The following is a description of a gene set: Any voltage-gated ion channel activity that is involved in regulation of postsynaptic membrane potential. Mouse Gene Set: GOMF_VOLTAGE_GATED_MONOATOMIC_ION_CHANNEL_ACTIVITY_INVOLVED_IN_REGULATION_OF_POSTSYNAPTIC_MEMBRANE_POTENTIAL species: Mus musculus, and this is the list of marker genes: Kcnk1, Kcnc4, Kcna1, Kcnd2, Kcna2